The following is a description of a gene set: Human Gene Set: HP_SMALL_PITUITARY_GLAND Small pituitary gland An abnormally decreased size of the pituitary gland. studied in species Homo sapiens, and this is the list of marker genes: COG2, MED12, GNB2, FGF8, RBM28, VSX1, KIAA0753, MAGEL2, RNU4-2, ZFX, HS6ST1, MAST3, FANCI (NCBI Gene Id 751608), SIM1, GHSR, NDE1